The following is a description of a gene set: Any process that stops, prevents or reduces the frequency or rate of heart contraction. species: Homo sapiens Human Gene Set: GOBP_NEGATIVE_REGULATION_OF_HEART_RATE, and this is the list of marker genes: ADRA1A, PLN, AGTR2, GJD3, MIR26A1, SRI, RNLS, SPTBN4, SPX, TNF, FKBP1B, TAC1, NPFF